Given this list of marker genes H1-2, APOA2, PRDM1, NR2F2, IGLV4-69, CFB, JCHAIN, PPP1R2, PILRA, IL1RN, LANCL1, KNG1, MBNL2, SERPING1, CCR9, BASP1, GNAS, RYR2, SLC16A9, SRP54, IGHG1, CWC22, FAM209A, RELN, SOSTDC1, PON3, IGHG3, LIFR, HSPA4L, IGHM, IGHV3-72, MACC1, MAP3K6, SLPI, HSPA1A, here is a description of the gene set: The t(14;18)(q32;q21), resulting in deregulated expression of B-cell-leukemia/lymphoma-2 (Bcl-2), represents the genetic hallmark in human follicular lymphomas. Substantial evidence supports the hypothesis that the t(14;18) and Bcl-2 overexpression are necessary but not solely responsible for neoplastic transformation and require cooperating genetic derangements for neoplastic transformation to occur. To investigate genes that cooperate with Bcl-2 to influence cellular signaling pathways important for neoplastic transformation, we used oligonucleotide microarrays to determine differential gene expression patterns in CD19+ B cells isolated from Emu-Bcl-2 transgenic mice and wild-type littermate control mice. Fifty-seven genes were induced and genes were repressed by > or =2-fold in Emu-Bcl-2 transgenic mice (P < 0.05). The suppressor of cytokine signaling-3 (SOCS3) gene was found to be overexpressed 5-fold in B cells from Emu-Bcl-2 transgenic mice. Overexpression of Bcl-2 in both mouse embryo fibroblast-1 and hematopoietic cell lines resulted in induction of SOCS3 protein, suggesting a Bcl-2-associated mechanism underlying SOCS3 induction. Immunohistochemistry with SOCS3 antisera on tissue from a cohort of patients with de novo follicular lymphoma revealed marked overexpression of SOCS3 protein that, within the follicular center cell region, was limited to neoplastic follicular lymphoma cells and colocalized with Bcl-2 expression in 9 of 12 de novo follicular lymphoma cases examined. In contrast, SOCS3 protein expression was not detected in the follicular center cell region of benign hyperplastic tonsil tissue. These data suggest that Bcl-2 overexpression leads to the induction of activated signal transducer and activator of transcription 3 (STAT3) and to the induction of SOCS3, which may contribute to the pathogenesis of follicular lymphoma. species: Mus musculus Genes up-regulated in primary B lymphocytes engineered to overexpress BCL2. from publication Vanasse GJ, Winn RK, Rodov S, Zieske AW, Li JT, Tupper JC, Tang J, Raines EW, Peters MA, Yeung KY, Harlan JM (PMID 15561778) Human Gene Set: VANASSE_BCL2_TARGETS_UP